The following is a description of a gene set: Mouse Gene Set: GOBP_PYRIDINE_CONTAINING_COMPOUND_BIOSYNTHETIC_PROCESS species: Mus musculus The chemical reactions and pathways resulting in the formation of a pyridine-containing compound, i.e. any compound that contains pyridine or a formal derivative thereof., and this is the list of marker genes: Htt (NCBI Gene Id 319350), Bcl10, Bin1, Xiap, Naprt, G6pdx, Rac1, Ido1, Nampt, Afmid, Nadsyn1, Kmo, Nmnat3, Nadk2, Pnpo, Reg3g, Slc25a51, Idh2, Aspdh, Kynu (NCBI Gene Id 70789), Nmrk2, Nmnat2, E2f1, Pdxk, Ido2, Acmsd, Haao, Extl3 (exostosin-like glycosyltransferase 3), Nmnat1, Nadk, Qprt, Nmrk1